Given this list of marker genes PDCD4, PHYH, TBXAS1, FAM171A1, MARCHF8, PTAFR, IFNAR2, ZIC3, VCL, BTN3A2, HUNK, ZDHHC3, PCTP, EMILIN2, CDC14A, ARL15, BET1, TRIM44, ASS1, ZNF137P, SLC39A6, HNRNPA1, ZNF337, IL25, TBC1D5, HARS2, DSG1, TPSG1, SLTM, CLN5, TTC19, RTN2, SERINC3, DENND5A, SEL1L, SOCS5, LILRA3, PROCR, SPINT2, PTK2, EPS15, TMEM183A, SLC2A11, NXF2, RFPL1S, ZNF529, ZBTB18, MUC5AC, LPIN1, OPRL1, C1D, HOMER2, TCTA, KRT36 (NCBI Gene Id 8689), ZHX3, CCNL2, TSG101, TDP2, PEBP1, FBP1, CSRNP2, S100A14, VPS28, CAMSAP2, ZMYND8, CEP70, PHLDA2, HOXA9, GMPR, TDRD7 (tudor domain containing 7), CTSS, NFE2L2, HNMT, FAT1, DCAF6, IMPACT (impact RWD domain protein), YIPF1, B3GAT1, SCRN3, NFYB, BTBD1, CAPG, LYZ, BPI, TRIM13, CAMSAP1, HEXA, ZNF804A, GLUL, CRTAP, SH3BGRL, ASAH1, TRAM1, TMOD1, SLC10A3, DOP1A, DRAM1 (DNA damage regulated autophagy modulator 1), EIF4A2, GSE1, FAIM2, ALDH1A1 (aldehyde dehydrogenase 1 family member A1), PIGK, MEIS2, AHCYL2 (NCBI Gene Id 23382), OLFML2B, TIMP3, SLC35A2, DPYD, GNAS, HP, LAPTM4A, CHST15, BNC2, NPIPA1, CTNND1, KATNBL1, HBP1, LY75, CREG1, MARCHF3, NR0B1, ZSCAN26, EXOC1, MORC3, EPB41L3 (erythrocyte membrane protein band 4.1 like 3), ZMYND11, COLEC11, PPP4R3B, FCGR3B, TXNDC9 (thioredoxin domain containing 9), DROSHA, RABGEF1, ACBD3, SMPDL3A, SPATA2, RNLS, GNAQ (NCBI Gene Id 2776), RAB7A, FAM168B, BMS1P20, TREM2 (NCBI Gene Id 54209), MAGEC1, PLAT, ANXA1, TMEM123, DEPTOR, BCS1L, PLEKHF2, SOX13, PPM1H, UBE2D4, SPI1, HERC1, TSEN34, HEY1, ADAMTS3, SIRPB1, CD36, MYF5, LPGAT1 (lysophosphatidylglycerol acyltransferase 1), HOMER3, MT1M, VAT1, PGLS, LYST, CTNNA1, CRYGC, ZBTB20, DPY19L1, ATP5F1E, SCML1, YLPM1, LAMC1, ST13 (NCBI Gene Id 8937), PILRA (NCBI Gene Id 29992), ZNF24, MYL5, COG5, SERPINH1, ATG12, DLK1, CACNA1I, RHEB, PSMF1, DAZAP2, PBX3, AMHR2, PMEPA1, DES, HLCS, DAB2, RAC1, FMR1, GALC, ADCK2, CA12, MVB12B, SLC22A18AS, ATP12A, here is a description of the gene set: Genes up-regulated in comparison of mast cells versus Th1 cells. Human Gene Set: GSE3982_MAST_CELL_VS_TH1_UP studied in species Homo sapiens from publication Jeffrey KL, Brummer T, Rolph MS, Liu SM, Callejas NA, Grumont RJ, Gillieron C, Mackay F, Grey S, Camps M, Rommel C, Gerondakis SD, Mackay CR (PMID 16474395) In the present study we used Affymetrix oligonucleotide microarrays to produce gene transcription profiles for the major leukocyte types in humans. This comprehensive dataset enabled us to not only establish which genes were expressed in each leukocyte type, but also which genes were expressed in each subset after activation. The used of a comprehensive dataset of gene profiles from all the major human leukocyte subsets enabled a novel and powerful means for identification of genes associated with single leukocyte subsets, or different immune paradigms.